The following is a description of a gene set: species: Mus musculus The chemical reactions and pathways resulting in the breakdown of erythrose 4-phosphate/phosphoenolpyruvate family amino acid. Mouse Gene Set: GOBP_ERYTHROSE_4_PHOSPHATE_PHOSPHOENOLPYRUVATE_FAMILY_AMINO_ACID_CATABOLIC_PROCESS, and this is the list of marker genes: Gstz1, Ido1, Hpd (NCBI Gene Id 15445), Kmo, Hgd, Fah, Tdo2, Ido2, Kynu, Afmid, Il4i1 (interleukin 4 induced 1), Tat, Acmsd, Qdpr, Haao, Pah